Given this list of marker genes TEFM, ETNK1, SLC44A2, ARMCX4, VPS29, EHD3, LAS1L, ZNF329, SEPTIN2, C2orf76, DHPS, MIOS, YBX3, TRAP1, SPPL3, DOCK10, MRPL39, RBM22, ENPP4, PANK4, AZIN2, ZDHHC24, CDK10, TCOF1, ABI1, FAM120C, CLDND1, ADAM10, SMIM15 (small integral membrane protein 15), ARHGAP45, ADAM17, CMYA5, AGO1, NDUFAF4, RPS9, COX16 (NCBI Gene Id 51241), PREX1, PSME2, RNF114, PAIP2, ACAT1, BAHD1, BTBD1, RRP15, BLK, RPS25, ATP5MC2, ANKRD11, CLNS1A, OTUD5, TCF25 (NCBI Gene Id 22980), BTG3, HTRA2, RTRAF, MRPL32, ARHGEF10L, HMGN3, RELB (RELB proto-oncogene, NF-kB subunit), SIRT7, AP1AR, C1QA, CNPY4, SLC39A4 (solute carrier family 39 member 4), EPB41L2, SLFN13, NELFB, RWDD1, DHX36, ADO, TAP2, STK10 (serine/threonine kinase 10), FOXA3, NME7, COX17, ARHGAP18, PARK7, LY96, NLK, ANKRD44, CREBRF, CNDP2, EI24, KLHL42, RRAD, FZD7, ESCO1 (NCBI Gene Id 114799), PUS3, RPS16, MGA, ZDHHC15, METTL23, PURA, RBM41, ATP5PB, GATA3, CAMK2B, BCLAF1, TWF1, TOMM22, DENND4C, MAP7D1, NEMF, ODC1, NDUFB5, SON, RRP7A, PSMA4, DUS3L, NMI, UROD, FARP2, SSTR4, TTC14, MAF, MIF, ZNF569, TACC1, DYNC1H1, CSNK1A1, ASXL2, ZC2HC1A, MTARC2, PHF6, CSDE1, MRTO4, CMKLR1, TNFRSF18, SORBS1, NEK3, TXNIP, ARHGAP30, BRF1, NUDC (nuclear distribution C, dynein complex regulator), MAP3K2, GLRX5, SACS, TNFRSF25, RPS10, THUMPD1 (NCBI Gene Id 55623), DDX24, HLA-E, LAIR1, TEX10, PPRC1, C22orf39, NFIX, NDUFA12, ERAP1, SSH2, PUS1, PYCARD, L1CAM, PLPP6, SH3GLB1, CCT6A (chaperonin containing TCP1 subunit 6A), RAB10, NUDT1, TBC1D10C, ENY2, NRF1, ATP5F1D (ATP synthase F1 subunit delta), TRIM28, EIF3A, LRWD1, FAU, MAP4K1, SMIM20, AFG1L, FAM135A, TRIM44, JAGN1, ACVR2A, UBA3, SPRY2, KLF10, C19orf48P, ELOVL5, RPS27, BRD2 (bromodomain containing 2), NRBF2, EFR3A, MTHFD1, TOGARAM1, ABI2, G3BP2, TIA1, STARD10, PPIE, BBX, MSH2, ZBTB7A, PLXNB2, HYPK, RCL1, SSR2, GALNT12, CDC5L, MEF2C, SNX33, PIGF, here is a description of the gene set: species: Homo sapiens from publication Konuma T, Nakamura S, Miyagi S, Negishi M, Chiba T, Oguro H, Yuan J, Mochizuki-Kashio M, Ichikawa H, Miyoshi H, Vidal M, Iwama A (PMID 21540074) Genes up-regulated in comparison of NK cells versus monocyte macrophages. Human Gene Set: GSE27786_NKCELL_VS_MONO_MAC_UP Each fraction of mouse hematopoietic cells was purified by cell sorting from bone marrow of 8-week-old C57BL/6 mice, and its gene expression was analyzed.